The following is a description of a gene set: species: Homo sapiens Human Gene Set: REACTOME_FORMATION_OF_XYLULOSE_5_PHOSPHATE Formation of xylulose-5-phosphate, and this is the list of marker genes: CRYL1, SORD, AKR1A1, XYLB, DCXR